Given this list of marker genes Egf, Tgfa, Adam17, Bace1, Myoc, Mapk3, Btc, Egfr, Erbb2, Sos1, Hbegf, Map2k1, Nrg1, Cpne3, Mapk1, Adam10, Nrg2, Ereg, Erbb3, Areg, Map2k2, Grb2, Raf1, Erbb4 (erb-b2 receptor tyrosine kinase 4), Ptprr, Hras, here is a description of the gene set: species: Mus musculus The series of molecular signals initiated by binding of a ligand to the tyrosine kinase receptor ERBB2 on the surface of a cell. The pathway ends with regulation of a downstream cellular process, e.g. transcription. ERBB2 receptors are themselves unable to bind to ligands, but act as a signal-amplifying tyrosine kinase within a heterodimeric pair. Mouse Gene Set: GOBP_ERBB2_SIGNALING_PATHWAY